The following is a description of a gene set: species: Mus musculus Any peptidyl-tyrosine dephosphorylation that is involved in inactivation of protein kinase activity. Mouse Gene Set: GOBP_PEPTIDYL_TYROSINE_DEPHOSPHORYLATION_INVOLVED_IN_INACTIVATION_OF_PROTEIN_KINASE_ACTIVITY, and this is the list of marker genes: Ptprh, Ptprj, Ptpro, Acp4, Ptprb, Ptprt, Dusp10, Dusp3 (dual specificity phosphatase 3 (vaccinia virus phosphatase VH1-related))